The following is a description of a gene set: Mouse Gene Set: GOMF_STEROL_BINDING Binding to a sterol, a steroid containing a hydroxy group in the 3 position, closely related to cholestan-3-ol. species: Mus musculus, and this is the list of marker genes: Nfe2l1, Sult2b1, Npc1, Stard6, Minar2 (membrane integral NOTCH2 associated receptor 2), Erlin2, Tmem97, Gramd1c, Npc1l1, Apod, Rorc, Anxa6, Stard4, Sidt1, Soat1, Gpr155, Gramd1a, Osbpl3, Osbpl1a, Scarb2, Pmp2, Vdac1, Cyp11a1, Cav1, Insig1, Ninj2, Ptch1, Osbpl10, Erlin1, Osbpl5, Osbpl6, Cd81, Gpr183, Osbpl9, Smo, Apoa1, Ephx1, Osbpl7, Prom2, Osbp2, Scp2, Insig2, Gramd1b, Soat2, Gpr141, Stard5, Tspo2, Stard3, Stard3nl, Osbpl8, Apoa2, Star, Vdac2, Npc2, Syp, Osbpl2, Crp, Slc38a9, Rora, Gas1, Osbp, Prom1, Osbpl11, Tmem199 (transmembrane protein 199), Scap